The following is a description of a gene set: Human Gene Set: HP_FEMALE_EXTERNAL_GENITALIA_IN_INDIVIDUAL_WITH_46_XY_KARYOTYPE studied in species Homo sapiens The presence of female external genitalia in a person with a male karyotype. Female external genitalia in individual with 46,XY karyotype, and this is the list of marker genes: MAP3K1, CYP11A1, AR, DHX37, HSD3B2, CYB5A, GATA4, WWOX, SRY, VAMP7, SOX9, ZFPM2, HSD17B3, CYP17A1, NR5A1, WT1, NR0B1